Given this list of marker genes PLA2G6, JRK, SARDH, VPS41, TUBG1, CACNA1H, NIPA1, FRMD5, VPS13D, TCF12, TREM2 (triggering receptor expressed on myeloid cells 2), SPTAN1, OPA3, SPTBN1, SLC2A1, CHMP2B, DNAAF4, PSEN1, GABRB3, MAPT, MAP1B, VCP, NIPA2, TMEM106B, STIM1, GABRA1, GABRG2, APC, GRN, SQSTM1, PNKP, GCLC (glutamate-cysteine ligase catalytic subunit), here is a description of the gene set: Dyslexia A learning disorder characterized primarily by difficulties in learning to read and spell. Dyslectic children also exhibit a tendency to read words from right to left and to confuse letters such as b and d whose orientation is important for their identification. Children with dyslexia appear to be impaired in phonemic skills (the ability to associate visual symbols with the sounds they represent). studied in species Homo sapiens Human Gene Set: HP_DYSLEXIA